The following is a description of a gene set: studied in species Mus musculus Any process that initiates an immune response. Mouse Gene Set: GOBP_ACTIVATION_OF_IMMUNE_RESPONSE, and this is the list of marker genes: Pik3ap1 (NCBI Gene Id 83490), Laptm5, Foxp3, Fpr3, Scimp, Tlr1, Zdhhc1, Gm12250, Tifa, Ighm (immunoglobulin heavy constant mu), Cd300ld, Letmd1, Smpdl3b, Trat1, Slc46a2, Pycard, Csk, Ifi35, Cyld, Fcer2a, Fpr-rs7, Cfp, Tmem126a, Usp9x, Rigi, Tlr6, Ddx3x, Nras, Lamp2, Itpripl1, Gpr108, Cgas, Ighg2b, Ifng, Eif2b4, Sppl3, Hras, Eif2b1, Trim30c, Rela, Psen1, Slc15a2, Clpb, Bcar1, Gbp3, Nfkbiz, C1rb, Ppp2ca, C9 (complement component 9), Gcsam, Vtcn1, Zbp1, Tax1bp1, Cr2, Mog, Cd300ld3, Znrf1, Lrrc14, Xrcc6, Btnl6, Tlr4, Ikbkg, Gbp2b, C6, Mavs, Usp17le (ubiquitin specific peptidase 17-like E), Mark4, C5ar2, Zp3r, Tifab, Btn2a2, Btrc, Rab29, Cd160, Cd300ld4, Ptpn22, Krt1, Ifi203, Cblb, Rsad2, Ncr3-ps, Rbm14, Lats1, Irf4, Vsig4, C2, Ccdc134, Oas1d, Cd81, Spsb3, Rps3, Tnip1, Cmtm3, Fcna, Sqstm1, Lgals3, Cd226, Themis3, Sec14l1, Cd247, Bcl10, Lsm14a, Tlr11, Irgm1, Nlrc3, Pqbp1, Pum1, Lax1, Riok3, Trim25, Tespa1, Tlr3, Tarbp2, Skint5 (NCBI Gene Id 670512), Ifi207, Cyba, Cd79a, Ceacam1, Lbp, Icosl, Ffar2, Skap1, Dhx33, Nfatc2, Nr4a3, Elf1, Skint8, Trim5, C3ar1, Klrc3, Pik3r1, Oas3, Ap3b1, Cfi, Klri1, Cactin, Nod1, Masp2, Psen2, Skint11, Rab7b, Skint3, Ecsit, Gm15441, C1s2, Ifi205, Elp6, Blnk, Pde4b, Hexim1, Tirap, Zcchc3, Ubr2, Ddx60, Ticam1, Tyro3, Stmp1, Khdrbs1, Klrc2, Klrd1, Irak1, Zdhhc9, Plscr1, Cr1l, Masp1 (NCBI Gene Id 17174), Nlrp10, Tec, C8b, Fpr-rs3, Cd5l, Sin3a, D1Pas1, Rgcc, Arf6, Ltf, Fcrl5, Wdfy1, Prnp, Lcp2, Colec11, Pja2, Nlrc4, Lpxn, Tnfaip3, Cav1, Tril (NCBI Gene Id 66873), C4bp, Pcbp2, Ripk2, Ywhae (NCBI Gene Id 22627), Usp46, Lrrc19, Tomm70a, Irgm2 (immunity-related GTPase family M member 2), Hsp90aa1, Aurkb, Btk, Nono, C8g, App, S100a14, Ctla4, C1qc, Cd19, Tnf, Zdhhc5, Gps2, Cfhr2, Ifi214, Rab11fip2, C5ar1, Mfhas1, Colec12, Cd300a, Cd59a, Nod2, Chuk (conserved helix-loop-helix ubiquitous kinase), Sting1, Lyn, Rabgef1, Alpk1, Slc15a3 (solute carrier family 15, member 3), Ipo5, Thy1, Irf2 (interferon regulatory factor 2), Dgkz, Gata3, Hmgb1, Appl1, Abl1, Fpr-rs4 (NCBI Gene Id 14291), Ptpn6, Gkn2, Naglu, Skint6, Tnip2, Ankrd17, Slc15a4, Bcl2, Ppp6c, Fosl2, Arrb2, Hspa8, Cd274, Lgr4, Cmklr1, Blk, Cd300ld2, Irf7, Dab2ip, Plcg2, Znfx1, C3, Fcmr, Igha, Mapkapk2, Lime1, Rnf135, Nr1h3, Ticam2, S100a9, Klre1 (killer cell lectin-like receptor family E member 1), Nos2, Nmi, Trim3 (tripartite motif-containing 3), Mndal, Ada, Nlrp1b, Themis, Atat1, Rnf170, S100a8, Bag6, Nagk, Rnf115, Trav7-2, Stoml2, Themis2, Brcc3, Kcnk13, C4a, Plscr2 (phospholipid scramblase 2), Slc19a1, Rbck1, Sos1, Gpatch3, Bpifb1 (NCBI Gene Id 228801), Cd22, Ninj1, Aars2, Abhd17a, Prkce, Tlr5, Kcnn4, Gbp7, Btnl10, Gpr33, Nfkbil1, Grb2, Mapk8, Matr3, Shb, Dusp22, Cd2ap, Skint1, Klhl6, Reg3g, Bcl2a1d, C1qbp, Btnl2, Cd79b, Smpdl3a, Ezr, Nfkb1, Ubash3a, Trem2, Cacnb4, Tab1, Lrrfip2, Plcg1, Casp6, Csnk1a1 (NCBI Gene Id 93687), Ms4a1, Tkfc, Ptgs2os (NCBI Gene Id 639611), Oasl1, Cd8a, Tlr8, Clec4e, Tlr7, Syk, Src, Gpld1, Oas1a, Zfp683, Prkcb, Cfd, Sh2b2, Gramd4, Ccr7, Mapk1 (mitogen-activated protein kinase 1), Tnip3, Nfkbid, Ighg1, Tnfrsf21, Map3k7, Lilrb4a, Klrc1, Cd3e, Cfhr4, Sh2d1a, Ighg3, Brcc3dc, A2m, Rnf34, Gdi1, Cd28, Tspan6, Traf6, C4b, Nlrp6, Ifi209, Ighe, Malt1 (NCBI Gene Id 240354), Hspa1b, Irf1, Ptpn2, Hc, Blvra, Ifi211, Skint2, Pawr, Zc3hav1, Xrcc5 (NCBI Gene Id 98297), Clec4n, Zdhhc18, Skint7, Usp50, Ifi213, Ufd1, Ubqln1, Trim15, Braf, Ifih1, Fcnb, Cd14, Plekha1, Casp4, Igtp, Sirt2, Epg5, Mbl2, Rap1a, P2rx7, Tlr2, Irak3, Btnl4, Colec10, Oas1f, Treml4, Nek7, Lacc1, Ptprc, C8a, C7, Rc3h2, C1rl, Oas1h, Btnl1, Card11, Cd276, Irak2, Rps6ka3, Skint10, Dennd1b (NCBI Gene Id 77060), Prkdc, Nr1d1, Ogt, Ptprs, Pdpk1, Flot1, Slc39a6, Tasl, Stk11, C1qa, Itgam, Mbl1, Kcnj8, Il1b, Ly96, Ube2n, Peli1, Nfkbia, Cd38, Trim30d, Trim12c, Erbin, Tmigd3, Cptp, Dhx58 (NCBI Gene Id 93832, DExH-box helicase 58), Ighg2c, Usp15, Lat, Usp12, Susd4, C1qb, Lyplal1, Bax (NCBI Gene Id 12028), Prkd2, Btnl12, Myo1g, Pram1, Klri2, Rtn4, Lrch4, Nfam1, Cd300lb, Trex1, Traf3ip3, Rftn1, Mapkapk3, Trim30b, Clec7a, Pum2, Nlrp1a, Foxp1, Klrk1, Fbxl2, Zap70, Btn1a1, Cd55b, Tlr12, Cd36, Plcl2, Cd55, Gbp2, Sfpq, Crp, Hcfc2, Ifi203-ps, Pde4d, Fyb2, Slc39a10, Appl2, Zc3h12a, Inava, Nploc4, Cd46 (CD46 antigen, complement regulatory protein), Cd86, Oas1c, Esr1, Otulin, Trim12a, Cd59b, Txk, Nck1, Traf3, Trim11, Bmx, Skint4, Eif2b3, Lilrb4b, Gfi1, Pspc1, Fpr2, Ikbke, Tbk1, C1s1, Otud4 (OTU domain containing 4), Phpt1, F2rl1, Ptprj (NCBI Gene Id 98976), Gbp5, Fosl1, Havcr2, Zdhhc3, Aim2, Clec2i, Becn1, Nectin2, Akt1, Rapgef1, Mefv, Ifi204, Oas1e, Phb2, Cd47, Skint9, Tyrobp (TYRO protein tyrosine kinase binding protein), Eif2b5, Lck, Eif2b2 (eukaryotic translation initiation factor 2B, subunit 2 beta), Mef2c, Phb1, Crkl, Hspd1, Znrf4, Nr1h4, Cd300lf, Tlr9, Nckap1l, Parp1, Fyb1, Itch, Trim32, Fcho1, Cd8b1, Ermap, Irf3, Dusp3, Fpr-rs6, Pvrig, Trim31, Rc3h1, Ppt1, Prkd1, Serping1, Myd88 (myeloid differentiation primary response gene 88), Stap1, Ifi208, Washc4 (NCBI Gene Id 319277), Sla2, Banf1, Btnl9, Oas1b, Xiap, Fyn, Nlrx1, Zdhhc12, Carmil2, Pten, Rnf31, Nop53, Tlr13, Fpr1, Vav3, Oas1g (2'-5' oligoadenylate synthetase 1G), Itk, Cfb, C1ra, Prkch, Cfhr1, Cfh, Casp1, Sarm1 (NCBI Gene Id 97709), Nlrp3, Trim30a, Unc93b1, Rnf144a, Rnf125, Lipa, Ifi206, Fcer1g, Eif2ak2, Cacnb3, Lats2, Lat2, Wnk1, Peli3, Acod1